Given this list of marker genes CUBN (cubilin), CBLIF, AMN (amnion associated transmembrane protein), here is a description of the gene set: Defects in AMN cause recessive hereditary megaloblastic anemia 1 (RH-MGA1 aka MGA1 Norwegian type or Imerslund-Grasbeck syndrome, I-GS; MIM:261100). The Norwegian cases described by Imerslund were due to defects in AMN. The resultant malabsorption of Cbl (vitamin B12) leads to impaired B12-dependent folate metabolism and ultimately impaired thymine synthesis and DNA replication. Reactome Pathway: Defective AMN causes MGA1 part of: Defects in cobalamin (B12) metabolism species: Homo sapiens